Given this list of marker genes Tmem238l, Creb3l1 (NCBI Gene Id 26427), Itpr1, Xbp1, Map3k5, Bag6, Ptpn2, Atp2a3, Trib3, Ern1, Nck1, Creb3, Fcgr2b, Selenok, Eif2ak3, Grina, Ikbkg, Aifm1, Opa1, App, Ins2 (insulin II), Rnf183, Casp12, Apaf1, Bax, Lrrk2, Casp9, Sirt1, Syvn1, Bbc3, Casp3, Atf4, Ube2k, Ern2, Wfs1, Tnfrsf10b, Bak1, Pdx1, Pml, Gsk3b, Park7, Herpud1, Dnajc10, Hyou1, Spop, Ptpn1, Trp53, Atp2a1, Chac1, Brsk2 (NCBI Gene Id 75770), Qrich1, Bcl2, Bcl2l1, Erp29, Serinc3, Bok, Txndc12, Tmbim6, Ero1a, Cebpb, Ddit3, Dab2ip, Nck2 (NCBI Gene Id 74592), Pmaip1, Selenos, Prkn, Rnf186, Tmem117, here is a description of the gene set: Mouse Gene Set: GOBP_INTRINSIC_APOPTOTIC_SIGNALING_PATHWAY_IN_RESPONSE_TO_ENDOPLASMIC_RETICULUM_STRESS species: Mus musculus The series of molecular signals in which an intracellular signal is conveyed to trigger the apoptotic death of a cell. The pathway is induced in response to a stimulus indicating endoplasmic reticulum (ER) stress, and ends when the execution phase of apoptosis is triggered. ER stress usually results from the accumulation of unfolded or misfolded proteins in the ER lumen.